The following is a description of a gene set: species: Mus musculus Mouse Gene Set: GOBP_NEGATIVE_REGULATION_OF_RESPONSE_TO_WOUNDING Any process that stops, prevents or reduces the frequency, rate or extent of response to wounding., and this is the list of marker genes: Epha4, Plau, Git1, Muc16, Fgf2, Fgb, Proc, Extl3, Dsg2 (desmoglein 2), Pdgfb, Pten, Serping1, Cd24a, Pros1, Reg3a, Smad3, F11, Rtn4r, Plat, Mmrn1, Prkcd, Rtca, Fga, Ceacam1, Wnt4, Tmprss6, Ptprs, Tpsab1, Myoz1, Apoe, Hrg, Gp5, Neo1, Rtn4rl1, Adamts18, Psg23, Xylt1 (xylosyltransferase 1), Ptpn6, Cldn19, Plaur, Cd9, Apoh, Pdgfra, D130043K22Rik, F2, C1qtnf1 (C1q and tumor necrosis factor related protein 1), Il17a, Plg, Cd109, Prkg1, Tfpi, Alox12, Inpp5f, Tafa5, Ubash3b, Cers2, Anxa5, Siglecg, Serpinf2, Ajap1, Alox5, Anxa2 (annexin A2), Serpine2, F12, Gp1ba, Tspan8, Cpb2, Slc12a2, Adtrp, Pdgfa, Thbd, Kremen1, Rgma, Wfdc1, Il33, Tnf, Fgg, Crk, Thbs1, Clasp2, Sh2b3, Tnr (NCBI Gene Id 21960), Kng1, Eppk1, Clasp1, Reg3g, Klkb1, Phldb2, Mdk, Tmx1, Lrig2, Cask, Vtn, Cldn3, Serpine1, Stat3, Kng2